Given this list of marker genes Osgin1, C3, Oaz1, Get3, Psmb8, Arhgap44, Pdcd2, Pnliprp2, Dtx3, Ly6a, Tmed9, Tle5, Ppp1r35, Sfrp5, Gng10, Paip1, Bend5, Csf2ra, Tmem59, Inpp4a, Gnb1, Rita1, Ywhae, Selenom, Hprt1, Zscan26, A430005L14Rik, Gadd45gip1, Prr13, Qsox1, Cytl1, Cpb1, Paqr6, Gstm1, Wbp2, Marf1, Ift27, Znhit1, Fxyd1 (FXYD domain-containing ion transport regulator 1), Bcl9l, Szrd1, Ngf, Vps72, Rheb, Ranbp1, Pnliprp1, Krt18 (NCBI Gene Id 16668), Etfa, Nsd3, Kdm6b, Gstm2, Pfdn1, Smagp, Fos, Commd10, Naa80, Gsn, Cfl1, Lrrc8a, Adrm1, Atp5mc2, Irf2bp2, Gm20300, Cpa2, Gadd45b, Drap1, Emc7, Myo10, Tcf7l2, Abl1 (c-abl oncogene 1, non-receptor tyrosine kinase), Rnaset2b, Rrp1, Nucb2, Spag7, Ifitm2 (interferon induced transmembrane protein 2), Spr, Arhgdia, Tmem37, Ndufa9, Il34, H2-D1, Bst2, Selenok, Fuz, Prdx5, Bri3, Chchd10, Fnbp1l, Rbp1, Gps2, Thap3, Rasl11a, Ccnd2, Dapk3, Lgals3bp, Rpl13a, Tmem176a, Jund, Ssbp1, Atn1 (NCBI Gene Id 13498), Zcrb1, Polr3gl, Calm2, Nop53, Snrpc, Mcfd2, Spry2, Capsl, Morf4l1, Cbx7, Sycn, Smim19, Smco4, Gjb1, Zfp704, Tmem176b, Selenow, Ubl7, Sod1, Eloc, C2cd4b, Scand1, F11r, Anapc11, Adam33, Phb2, Gabarapl1, Ptms, Dynll2, Zfp787, Ifi35, Cald1, Lurap1l, Emd, Adh1, Cirbp, Rtp4, Mmp7, Erh, Dpt, Arl3, Cd9, Cfap298, Tsc22d4, Zfp414, Cic, Elof1, Eif1, Rps7, Pfdn6, Nfkbib, Pomp, H2-K1 (histocompatibility 2, K1, K region), Wbp4, Ybx1, Akt1s1, Nfic, Chchd2, Hmg20b, Sptssa, Chd6, Tmsb4x, Nr2f2, Nupr1, Fkbp2, Ifitm3, Rnf126, Slc25a3, Mapk3, Cel, Cpa1, Fus, Ftl1, Sat1, Rpl13 (ribosomal protein L13), Igfbp7, Cdc37 (NCBI Gene Id 12539), Fth1, Macrod1, Rhoc, Ube2m, Sdc4, Prdx1, Mgst1, Dbndd2, Cryab (crystallin, alpha B), 0610010K14Rik, Ssbp3, Tm4sf1, Eno1b, 2610528J11Rik, Rpl6, Bcap31, Txn2, Mmp24os1, Tmem160, Tsc22d1, H2-Q6, Nav2, Dad1, Rtf1, Aldh2, Smdt1, Pebp1, Bsg, Cldn3, Sf3b2, S100a16, Gpx4, Tmem9, Cdc42ep5, Gabarapl2, Sf3b4, Pfn1, Lamtor4, Swi5, Plet1, B2m, Manbal, Lrrc75a, Sdhc, Tmsb10, Rbm26, Psma2, Eif5a, Cd63, Rpl4, Ifi27, Slc25a5 (solute carrier family 25 (mitochondrial carrier, adenine nucleotide translocator), member 5), Kdsr, Ier2, Selenos, Ctsh (NCBI Gene Id 13036), Map1lc3a, Ccdc198, Clec1a, Cyba, Rab5c, Nectin2, Reep5, Tomm6, Ubb, Rps3a1, Nr2c2ap, Eapp, Echdc2, F8a, Npm1 (nucleophosmin 1), Ino80e, Use1, Hhex, Ergic1, Bcl7c, Ambp (NCBI Gene Id 11699), Kdelr1, Znrf3, Csnk2b, Zfp36, Ppa1, Rplp0, Lmo4, Sfn, Wiz, Laptm4a, Rpl7l1, Cpeb3, Cdkn2c, Sumo1, Gsta3, Ldhb, Cavin1, Igsf5, Ngp, Rps3, Ddah2, Nabp2, Jag1, Ubb-ps, Kpna4, Ptma, Lcn2, Pex14, Oaz2, here is a description of the gene set: Mouse Gene Set: TABULA_MURIS_SENIS_PANCREAS_PANCREATIC_DUCTAL_CELL_AGEING from publication Tabula Muris Consortium (PMID 32669714) studied in species Mus musculus